Given this list of marker genes ZNF595, SRD5A3 (NCBI Gene Id 79644), AIF1, PLBD1, EMC1, COMT, GATM, PLAAT3, MSR1, SLC7A7, TXNIP, BCKDHB, AXL, RCN1, ACSS1, GALNT11, SFI1, CAPN5, ABHD1, SLCO2B1, TM7SF3, TUBB2B, ALAD, CNRIP1, SLC35A1, CD59, FGD2, KCNJ10, NRCAM, CXCR4, LYPLAL1, PIK3AP1, CBX6, HMGN3, CADM1, HLA-DQA2, LAMA3, PPP2R5C, ENO2, LCORL, PIANP (NCBI Gene Id 196500), RAB10, ARSB, COLEC12, ATP6V0E2, NAT8L, BLOC1S6, DYNLT1, RCBTB2, GDA, ACYP2, FAM9A, MARCKSL1, TGFBI, HAUS2, GLO1, TTC3, OGFRL1, ABCA9, CLBA1, CFH, RASAL2, HDDC3, GJA1, GNB4 (NCBI Gene Id 59345), CXCL14, ARFGEF3, OCEL1, RFX3, PTGER3, FAM135A, DST, CAP1, ADA, RPL14, TOR3A, P2RY13, RAPSN, FAM124A, MARCO, CRIM1, FILIP1L, TIFAB, PLXDC2, MALAT1, MAF, here is a description of the gene set: Human Gene Set: COATES_MACROPHAGE_M1_VS_M2_UP from publication Coates PJ, Rundle JK, Lorimore SA, Wright EG (PMID 18199539) In addition to the directly mutagenic effects of energy deposition in DNA, ionizing radiation is associated with a variety of untargeted and delayed effects that result in ongoing bone marrow damage. Delayed effects are genotype dependent with CBA/Ca mice, but not C57BL/6 mice, susceptible to the induction of damage and also radiation-induced acute myeloid leukemia. Because macrophages are a potential source of ongoing damaging signals, we have determined their gene expression profiles and we show that bone marrow-derived macrophages show widely different intrinsic expression patterns. The profiles classify macrophages derived from CBA/Ca mice as M1-like (pro-inflammatory) and those from C57BL/6 mice as M2-like (anti-inflammatory); measurements of NOS2 and arginase activity in normal bone marrow macrophages confirm these findings. After irradiation in vivo, but not in vitro, C57BL/6 macrophages show a reduction in NOS2 and an increase in arginase activities, indicating a further M2 response, whereas CBA/Ca macrophages retain an M1 phenotype. Activation of specific signal transducer and activator of transcription signaling pathways in irradiated hemopoietic tissues supports these observations. The data indicate that macrophage activation is not a direct effect of radiation but a tissue response, secondary to the initial radiation exposure, and have important implications for understanding genotype-dependent responses and the mechanisms of the hemotoxic and leukemogenic consequences of radiation exposure. Up-regulated genes distinguishing between M1 (pro-inflammatory) and M2 (anti-inflammatory) macrophage subtypes. studied in species Mus musculus